The following is a description of a gene set: studied in species Homo sapiens Human Gene Set: GOBP_RESPONSE_TO_PEPTIDOGLYCAN Any process that results in a change in state or activity of an organism (in terms of movement, secretion, enzyme production, gene expression, etc.) as a result of a peptidoglycan stimulus. Peptidoglycan is a bacterial cell wall macromolecule., and this is the list of marker genes: MYD88, CARD9, TREM2, IL6, C5AR1 (NCBI Gene Id 728), IRF5, DEFB124, CAMP, IRAK3, RELA, INAVA, RIPK2, NOD2